The following is a description of a gene set: Increased circulating troponin T concentration species: Homo sapiens Human Gene Set: HP_INCREASED_CIRCULATING_TROPONIN_T_CONCENTRATION An increased concentration of tropnin T in the blood, which is a cardiac regulatory protein that controls the calcium mediated interaction between actin and myosin. Raised cardiac troponin concentrations are now accepted as the standard biochemical marker for the diagnosis of myocardial infarction., and this is the list of marker genes: PSMB9, TTR, NPPA, HMGCR, SCN5A